The following is a description of a gene set: Human Gene Set: GOMF_VITAMIN_B6_BINDING Binding to a vitamin B6 compound: pyridoxal, pyridoxamine, pyridoxine, or the active form, pyridoxal phosphate. species: Homo sapiens, and this is the list of marker genes: AGXT2, ETNPPL, GOT1L1, GOT2, PYGB, SHMT1, GPT, AGXT, HDC, PDXDC1, SDSL, GLDC, DDC, PLPBP (NCBI Gene Id 11212), SRR, SCLY, SDS, ENSG00000274276, CISD1, CTH, GAD2, KYAT1, SGPL1, PYGM, ALAS2, TAT, SPTLC3, PSAT1, SPTLC2, PNPO, SPTLC1, OAT, GADL1, CSAD, KYNU, PDXDC2P-NPIPB14P, SHMT2, GAD1 (glutamate decarboxylase 1), PDXK, GPT2, CBS (cystathionine beta-synthase), MTARC2, ABAT, KYAT3, THNSL2, NFS1 (NCBI Gene Id 96810), ACCSL, PYGL, ALB, MOCOS, GOT1, ACCS, PHYKPL, GCAT, MTARC1, ALAS1, AADAT